Given this list of marker genes Dsp, Dsc2, Ctnna3, Jup, Dsg2, Pkp2, Cxadr (coxsackie virus and adenovirus receptor), here is a description of the gene set: Mouse Gene Set: GOBP_CARDIAC_MUSCLE_CELL_CARDIAC_MUSCLE_CELL_ADHESION The attachment of one cardiomyocyte to another cardiomyocyte via adhesion molecules. studied in species Mus musculus